The following is a description of a gene set: species: Homo sapiens Human Gene Set: GOCC_PROTEASOME_CORE_COMPLEX_BETA_SUBUNIT_COMPLEX The proteasome core subcomplex that constitutes the two inner rings of the proteasome core complex. An example of this component is found in Mus musculus., and this is the list of marker genes: PSMB4, PSMB5, PSMB8, PSMB1, PSMB3, PSMB9, PSMB6, PSMB10, PSMB11, PSMB7, PSMB2